Given this list of marker genes Gata3, Mir216a, Mir216b, Mir217 (NCBI Gene Id 387213), Gpc3, Bmp4, Osr1, Epha4, Wnt9b (NCBI Gene Id 22412), Hnf1b (HNF1 homeobox B), Efnb2, Pax2, Lhx1, Epha7, here is a description of the gene set: Mouse Gene Set: GOBP_NEPHRIC_DUCT_MORPHOGENESIS studied in species Mus musculus The process in which the anatomical structures of the nephric duct are generated and organized. A nephric duct is a tube that drains a primitive kidney.